Given this list of marker genes 4931408D14Rik, Cd200, Rnf128, Cpt1b (carnitine palmitoyltransferase 1b, muscle), Fam162a, Rnase1, Nkain3, Grm5, Cabcoco1, Gga3, Plagl2, Ppm1a, Edem1, Prok1, Or4c31, Abca3, Cks1b, Chrna10, Tnpo3, Clca3a1, Gsto1, Trpv4, Matn2, Rragd, Or2ag12, Ccnd2, Gm12236, Dlgap5, Gmnn, Or4k45, Id1, Pglyrp1, Srsf4, Rpl22l1, Ncoa3, Clca3a2 (chloride channel accessory 3A2), Arf3, Ccn5, Inpp5d, Pkdcc, Or2r11, Icos, Kif20a, Mapk6, St8sia6, Hs3st3b1, Ica1l, Tanc2 (tetratricopeptide repeat, ankyrin repeat and coiled-coil containing 2), 4930445N18Rik, Or1p1, Or52ac1, Or13c25, Rarg, Ankrd2, Upk1a, Creb3l4, Hint1, Tnrc6b, 4930456L15Rik, Myg1, Ppp2r5e, Glycam1, Ccser2, Prop1, C2, Tnfsf13, Mki67, Plscr1, Vwc2, Krtap6-3, 4930503L19Rik, Birc7, Nat8f4, Vpreb3, Btnl1, D430019H16Rik, Dcaf12l1, Vmn1r47 (NCBI Gene Id 113846), Pla2g2c, Dtx1, St6galnac2, Or8s10, Wscd1, Nid2, Slc39a8, Dnase2a, Mcm7, Dcpp2, Prpf4, Aknad1, Nup42, Nabp1, Galr3, Snhg11, Mfsd13b, Lrrc28, Cenpk, Rbp7, Chd3, Hells, Akr1c13, Shcbp1, Ldaf1, Hs3st3a1, Apoo, Tspan17, Or4c116, Rpl11, Syce2, B3gntl1, Spata19, Cip2a, Pla2g2e, Pip4p1, Aldh1a3, Nhlh1, Slc5a8, Angpt2, Hnrnpa2b1, Khdrbs3, Tnfrsf10b, Slit2, Krtdap, Ctsc, Fkrp, Tpst2, Mrpl35, Cux1, Gtsf1, Gm8096, Emb, Thap6, Elf4, Faim2, Slc15a1, Nek1, Chil3, Atp1b2, Six1, Mkln1 (NCBI Gene Id 319270), Cd36, Wnt10a, Zbtb45, Krtap5-3, Kremen1, Scd2, Dcpp1, Osbpl1a, Amdhd2, Itih5, Zbed5, Coro2b, Prim1, Nbea, Celsr2, P2ry2, Rcor1, Sycn, Ptk2b, Fdx1, Adam19, A2m, Arhgef28 (Rho guanine nucleotide exchange factor 28), Tmco5, Arhgap19, Gnmt, Med23, Ect2, Rbp1, Atf6, Abhd3, Spesp1, Atp11b, Dtl, Or6z6, Alox5ap, Defb15, Lrrc71, Aqp8, Nfia, Tspo2, Exosc7, 1700063H04Rik, Ccnb2, Creb5, Tmigd3, 4632427E13Rik, Or7g35, Glipr1, Abca2, Or2j3, Rab4b, Gm9873, Cfap251, Kif22, Mia, Tm7sf2, Caap1, Ermard, Spdef, Cdc26, Ncam1 (neural cell adhesion molecule 1), Trim45, Or4k36, Jpt2, Apom, Perm1 (NCBI Gene Id 74183), Or1f12, Tceal3, Cdhr5, Sybu, Or52e2, Odaph, Arhgef17, Rhog, Acvr1, Efhc1, Ilf2, Dmtn, Defb34, Lce1l (NCBI Gene Id 99618), Mgarp, Tpra1, Brca2, Gm13629, Or4c123, Cenpa, Sema3d, here is a description of the gene set: from publication Ray D, Terao Y, Fuhrken PG, Ma ZQ, DeMayo FJ, Christov K, Heerema NA, Franks R, Tsai SY, Papoutsakis ET, Kiyokawa H (PMID 17283130) studied in species Mus musculus Checkpoint pathways help cells maintain genomic integrity, delaying cell cycle progression in response to various risks of fidelity, such as genotoxic stresses, compromised DNA replication, and impaired spindle control. Cancer cells frequently exhibit genomic instability, and recent studies showed that checkpoint pathways are likely to serve as a tumor-suppressive barrier in vivo. The cell cycle-promoting phosphatase CDC25A is an activator of cyclin-dependent kinases and one of the downstream targets for the CHK1-mediated checkpoint pathway. Whereas CDC25A overexpression is observed in various human cancer tissues, it has not been determined whether deregulated CDC25A expression triggers or promotes tumorigenesis in vivo. Here, we show that transgenic expression of CDC25A cooperates markedly with oncogenic ras or neu in murine mammary tumorigenesis. MMTV-CDC25A transgenic mice exhibit alveolar hyperplasia in the mammary tissue but do not develop spontaneous mammary tumors. The MMTV-CDC25A transgene markedly shortens latency of tumorigenesis in MMTV-ras mice. The MMTV-CDC25A transgene also accelerates tumor growth in MMTV-neu mice with apparent cell cycle miscoordination. CDC25A-overexpressing tumors, which invade more aggressively, exhibit various chromosomal aberrations on fragile regions, including the mouse counterpart of human 1p31-36, according to array-based comparative genomic hybridization and karyotyping. The chromosomal aberrations account for substantial changes in gene expression profile rendered by transgenic expression of CDC25A, including down-regulation of Trp73. These data indicate that deregulated control of cellular CDC25A levels leads to in vivo genomic instability, which cooperates with the neu-ras oncogenic pathway in mammary tumorigenesis. Up-regulated genes in breast tumors from transgenic mice overexpressing ERBB2 and CDC25A compared to those from mice overexpressing ERBB2 only. Mouse Gene Set: RAY_TUMORIGENESIS_BY_ERBB2_CDC25A_UP